The following is a description of a gene set: Human Gene Set: REACTOME_HATS_ACETYLATE_HISTONES HATs acetylate histones species: Homo sapiens, and this is the list of marker genes: NCOA1, EPC1, H2BC15, H3C3, H2AC19, TAF10, H2AC11, JADE3, TADA2B, ELP1, H2AC4, TADA3, KAT2A, EP400, RUVBL2, ATF2, H3C11 (H3 clustered histone 11), CLOCK, KANSL2, H2BC10, KAT7, H2AC12, SAP130, KAT6B, H3C6, MORF4L2, ELP5, MRGBP, BRPF3, VPS72, WDR5, DR1, ENY2, H2AC18, H4C14, H2BC5, H3C8, KAT6A, BRD8, YEATS2, H2AC8, H2AC7, H2BC18, H3C1, H3C4, H2AC15, ZZZ3, PAX3, ATXN7L3, SUPT3H, H4C13, H2BC7, H2AC6, BRD1, H4C1, TAF12, H2AC16, H3C15, ING3, NCOA2, H4C2, SUPT7L, BRPF1, TADA1, H2BC1, JADE2, H3C13, H3C2, TAF6L, H3C12, KAT8, H2AC25 (H2A clustered histone 25), ELP2, SGF29, TAF5L, YEATS4, ACTB, EP300, H2BC13, H2AC17, H3C14, H2AC21, H4C3, USP22, H2BC21, H2BC9, KAT14, TRRAP, DMAP1, ACTL6A, ELP6, H2AC1, MSL2, TADA2A, H3C7, H2BC6, OGT, H4C9, MBIP, H2BC12, KANSL3, TAF9, H2BC8, ELP3, MORF4L1 (NCBI Gene Id 10933), H4C11, SUPT20H, MCRS1, H2BC3, H2BC26, H4C5, H2BC4, H4C4, H2AC13, RUVBL1, HCFC1, H2BC17, JADE1 (jade family PHD finger 1), PHF20, CREBBP, HAT1, KAT2B, H2BC11, H4C12, H4C8 (H4 clustered histone 8), H4C16, H2AC14, KAT5 (NCBI Gene Id 10524), MSL1, H2AC20, H3C10, ELP4, H4C6, ING4, MSL3, ING5, MEAF6, H2BC14, H4C15, ATXN7, RBBP7, KANSL1